Given this list of marker genes Tfcp2l1, Tdg, Nsun7, Isoc1, Gspt1, Serpinb6b, Brpf1, Pik3c2a, Klhl24, Hprt1, Fyn, Cracd, Zdhhc21 (NCBI Gene Id 68268), Grm8, Clvs1, Pde5a, Ugt8a, Mycl, Kat6b, Ssb, Gmfb, Rab30, Tpp2, Vps4b, Zfp946, Unc80, Lox, Donson, Hspa4, Tm9sf2, Yy1, Vmn1r132, Kpna1, Poglut3, Trim6, Serpinb9 (serine (or cysteine) peptidase inhibitor, clade B, member 9), Ppara, Ubxn7, Casp8ap2, Uba6, Foxo1, Htr2a, Slc19a2, Cntn1, Usp32, Arhgap15, Parp8, Senp7, Slc16a12, Sec24a, Spcs3, Arfgef2, Dact1, Pno1, Trpd52l3, Tm4sf1, Fat4, Kdm7a, Tha1, Ttc17, Ktn1, Pcdhb3, Ehbp1 (EH domain binding protein 1), Tmem50a, Scd1, Stau1, Cacna2d1, Snrnp48, Spopl, Dlg5, Pclo, Mctp1, Pde3b, Kansl1l, Rin2, Kat6a, Larp4, Tent4b, Vdac1, Dgkb, Bcl9, Sfrp1, Spen, Myo6, Lin7c, Rara, Ddx59, Vwde, Pdia4, Yipf3, Ube2e3, Cdh3 (cadherin 3), Fbn2, Tead1, Zfp462, Pacc1, Spag9, Hlf, Cilp, Slc23a2 (solute carrier family 23 (nucleobase transporters), member 2), Tbc1d20, Med30, Mbtd1, Matr3, Mon2, Usp39, Fam76b, Pnrc1, Tmem167, Ugt2b38, Star, Capza1, B4galt6, Sec14l1, Brinp3, Tet2, Tafa2, F2rl2 (NCBI Gene Id 268688), Bbx, Zfp467, Ttc14, Atp5mc2, Slc5a7, here is a description of the gene set: from publication Chen Y, Wang X (PMID 31504780) Genes predicted to be targets of miRBase v22 microRNA mmu_miR_16_1_3p in miRDB v6.0 with MirTarget v4 prediction scores > 80 (high confidence targets). Mouse Gene Set: MIR_16_1_3P studied in species Mus musculus